The following is a description of a gene set: Mouse Gene Set: GOBP_PLACENTA_DEVELOPMENT studied in species Mus musculus The process whose specific outcome is the progression of the placenta over time, from its formation to the mature structure. The placenta is an organ of metabolic interchange between fetus and mother, partly of embryonic origin and partly of maternal origin., and this is the list of marker genes: Rtcb, Tex19.2, Alkbh1, Fgfr2, Itgav, Vcam1, Ascl2, Kiss1, Spint1, Erf, Map3k4, Sp3, Sox15, Wnt2, Serpine1, Cited1, Rxrb, Ppard, Plcd1, Plg, Ctsl, Cts8, Stc2, Foxd3, Ghrl, Nr2f2, Zfp36l1, Hey2, Nsdhl, Ncoa6, Ndp, Ccnf (NCBI Gene Id 12449), Egfr, Ncoa3 (nuclear receptor coactivator 3), Mapk1, Bmpr2, Vwf, Ndrg3, Ggnbp2, Dedd (NCBI Gene Id 21945), Fzd5, Adm, Egln1, Epor, Parp2, Zfp568, Fbxw8, Grb2, Tppp3, Ncoa1, Pkd2, Pla2g4a, Mir127, Hsd17b2, Pcdh12, Esx1, Plcd3, Epas1, Ada, Ctsb, Map2k1, Ghsr, Etnk2, Plk4, Adam19, Pkd1, Krt8, Pbrm1, Prdx3, Etv2, Abcb1a (NCBI Gene Id 64575), St14, Pparg, Csf2, Rbpj (NCBI Gene Id 791349), Hif1a, Parp1, Arid1a, Tex19.1, Pdgfb, Ttpa, Vash2, Dcaf13, Prl7d1, Tmed2, Fosl1, Bmp7, Sap130, Arnt, Mc2r, Dnajb6, Sp1, Ovol2, Notch2 (NCBI Gene Id 99749), Cyp27b1, Rps6, Cdh1, Cdx4 (caudal type homeobox 4), Dazap1, Mdfi, Pcdha9, Lef1, Tfeb, Cts7, Ptn, Gcm1, Lhx3, Hectd1, Bmp5, Lhx4, Elf5, Nodal, Cdkn1c (NCBI Gene Id 12577), Wnt7b, Hs6st1, Stk4, Trim28, Lep, Akt1, Il11ra1, Il10, Stk3, Cdkn1b, Plac1, Hsf1, Igf2, Dnmt3l, Hes1, Gjb3, Phlda2, Ptgis, Cebpb, Rbm15, E2f7, Vdr, Bptf, Gja1, Syde1, Slc8a1, Krt19, Mapk3, Cdx2, Birc6, Esrrb, Xist, Senp2, Stc1, Ptgs2, Lif, Crxos (cone-rod homeobox, opposite strand), Fbn2, Itga4, Tcf23, Cul7, Gata2, E2f8, Ccn1, Cebpa, Mapk14, Vash1, Ash1l, Gab1, Nrk, Setd2, Junb, Llgl2, Spint2, Med1, Rspo3, Hey1, Cited2, Wdr83, Mme, Ccdc134, Dlx3, Pgf, Taf10, Met, Bsg, Rtl1, Grhl2, Prdm1, Htra1, Syna, Ldoc1, Stox2, Synb, Snai1, Hand1, Hnf1a, Peg10, Zfat, Birc2, Gjb5, Gjb2, Eomes, Gse1, Apela, Rxra, Hsp90ab1, Nfe2, Socs3